Given this list of marker genes DNMT1, SOD2, MIR221, MIR182, MIR214, OLFM2, MIR18A, PDGFB, MIR1-1, FGF9, MIR145, MIR140, here is a description of the gene set: studied in species Homo sapiens Human Gene Set: GOBP_REVERSIBLE_DIFFERENTIATION A phenotypic switching process where a cell reversibly differentiates and dedifferentiates from one cell type into another.